Given this list of marker genes Upb1, Upp1, Nt5c, Dpyd, Nt5m, Nt5c3, Upp2, Cda, Dpys, Tymp, here is a description of the gene set: The chemical reactions and pathways resulting in the breakdown of pyrimidine nucleoside monophosphate, a compound consisting of a pyrimidine base linked to a ribose or deoxyribose sugar esterified with phosphate on the sugar. studied in species Mus musculus Mouse Gene Set: GOBP_PYRIMIDINE_NUCLEOSIDE_MONOPHOSPHATE_CATABOLIC_PROCESS